The following is a description of a gene set: Human Gene Set: chr8q11 species: Homo sapiens, and this is the list of marker genes: BRIX1P1, NDUFA5P12, MTND1P7, ENSG00000253551, HSPA8P13, CEBPD, LINC02599, SPIDR, MAPK6P4, RNU105C, RNU6-665P, ALKAL1, ATP6V1G1P2, LINC02947, RNU6-1331P, ST18, ENSG00000253608, RNU6-656P, CLXN, LYPLA1, CRIPTOP5, ATP6V1H, ENSG00000308573, PSAT1P1, LINC00293, TRMT112P7, RPL34P17, RN7SKP32, SEC11B (SEC11 homolog B, signal peptidase complex subunit (pseudogene)), LINC03054, RB1CC1, MTND6P20, ENSG00000201316, TRIM60P15, RPL21P79, RNU6-519P, RNU6-819P, SNAI2, PPDPFL, BTF3P1, ENSG00000253782, MRPL15, PRKDC, RNU6ATAC32P, RPS27AP13, RN7SL250P, RPL10AP2, SOX17, NPBWR1, MAPK6P1, RFPL4AP7, PCMTD1 (protein-L-isoaspartate (D-aspartate) O-methyltransferase domain containing 1), CYCSP22, RGS20, ASNSP1, TCEA1, ENSG00000301980, RNU6-295P, MCM4, RN7SKP294, RNA5SP531, OPRK1, MTND2P38, PXDNL, LINC02984, ENSG00000306000, MTCYBP20, LINC02847, SNTG1, UBE2V2, IDI1P2, PCMTD1-DT, RPL29P19, ASNSP4, RP1, IGLV8OR8-1, ENSG00000286484